The following is a description of a gene set: Genes positively differentially expressed in cell type: cDC2 (conventional dendritic cell type 2) upon treatment with cytokine: IL-13 in mouse lymph nodes in vivo. Mouse Gene Set: CUI_CDC2_IL13_RESPONSE_UP from publication Cui A, Huang T, Li S, Ma A, Pérez JL, Sander C, Keskin DB, Wu CJ, Fraenkel E, Hacohen N (PMID 38057668) species: Mus musculus Cytokines mediate cell-cell communication in the immune system and represent important therapeutic targets. A myriad of studies have highlighted their central role in immune function, yet we lack a global view of the cellular responses of each immune cell type to each cytokine. To address this gap, the authors created the Immune Dictionary, a compendium of single-cell transcriptomic profiles of more than 17 immune cell types in response to each of 86 cytokines (>1,400 cytokine-cell type combinations) in mouse lymph nodes in vivo. A cytokine-centric view of the dictionary revealed that most cytokines induce highly cell-type-specific responses. For example, the inflammatory cytokine interleukin-1β induces distinct gene programmes in almost every cell type. A cell-type-centric view of the dictionary identified more than 66 cytokine-driven cellular polarization states across immune cell types, including previously uncharacterized states such as an interleukin-18-induced polyfunctional natural killer cell state., and this is the list of marker genes: Atp5mc1, Tbc1d16, Psmd1, Morf4l2, Calr, Timm13, Agpat5, Cct5, Rap1a, Rab3il1, Mrpl15, Gtf3c6, Cdh1, C1qbp, Lsm7, Vdac3, Uqcrc1, Syngr2 (NCBI Gene Id 20973), Pla2g12a, Srm, Hes6, Fbl, Psmd2, Rbx1, Trir, Naa10, Cd209e, Gsn, Uap1l1, Pfkp, Aqp3, Uqcr11, Tmem109, Snrpa, Cyb5r3, Rnf7, Pfn1, Pdia3, Ndufa12, Psmb5, AA467197, Pa2g4, Mgl2, Ndufa8, Hspd1 (NCBI Gene Id 15510), Ap2m1, Runx1, Prmt1, Matk, Efhd2, Pdia6, Hsp90ab1, Copz1, Mrc1, Sumo2, Psma7, Tm9sf3, Hnrnpc, Cfp, Timm8a1, Alyref, Vrk1, Nt5c, Sdhc, Park7, Sdf2l1 (NCBI Gene Id 64136), Snu13, Sdhb, Spint2, Tcea3, Glrx5, Mrpl12, Rfc1, Ssr2, Hnrnpk, Ppp1r14a, Hsp90b1, Csnk2b, Atp5pf, Psme3, Arf1, Ddost, Ptprf, Nrp2, Fcgrt, Srsf2, Spcs2, Llph, Aamp, Stt3a, Polr2g, Atp5f1a, Ndufb8, Eif3c, Serbp1, Gar1, Atp5mc3, Casp6, Selenos, Atic, Fkbp4, Slc29a1, Mdh2, Ostc, Hspe1, Gramd4, Bcl7c, Polr2f, Ak2, Tpm3, Jak2 (NCBI Gene Id 98155), Rpn1, Prelid1, Timm22, Spi1, Septin3, Fabp5, Cltc, Il4i1, Wdr18, Lsm4, Lgals1, Trappc2l, Gfra2, Pkm, Fh1, Nfu1, Pdia4, Mtx2, Wdr46, Hspa5, Mrpl54, Ccnd3, Adam8, Ybx1, Mrps28, Slc35b1 (NCBI Gene Id 22233), Tarm1 (NCBI Gene Id 245126), Cyc1, Gapdh, Wdfy4, Psmb10, Kynu, Atp5f1b, Smdt1, Cct3, Vps11, Hnrnpf, Serpina3g, Nop2, Psma2 (NCBI Gene Id 19166), Eif5a, Pecam1, Otulin, Ptges3, Phb2, Magoh, Eif4a1, Sf3b6, Mpc1, Foxn3, Cacybp, Hdgf, Apex1, Dad1, Nudt2, Chchd1, Slc29a3, Eprs1, Bax, Ndufb6, Batf3, Pfdn1, Set, Slc39a7, Edf1, Rsl1d1, Acat1, Ppp1r14b, Sdc4, Adam11, Stip1, Naa38, Nme1, Bola3, Ruvbl1, Bzw1, Krtcap2, Atp5pb, Glipr2, Slc15a3, Lsm2, U2surp, Eif1b, Qpct (glutaminyl-peptide cyclotransferase (glutaminyl cyclase)), Srsf3, Hnrnpab, Timm10b, Bcl11a, Eif1ax, Utp20, Macroh2a1, Ncor2, Psma3, Chchd10, Bcap31, Anp32b, Ndufb9, Mrps15, Hsp90aa1, Psmd4, Arl1, Hfe, Nudcd2, Snrpa1, Fyn, Ywhae, Manf, Psmb7, Lman1, Pdzd4, Cycs, Cdc37, Anpep, Ndufb4, Ldha, Creld2, Nans, Gnl1, Srp14, Rexo2, H13, Sf3b3, Daglb, Idnk, Cd9, Ift20, Bag1, Bzw2, Ctsz, Gadd45gip1, Snx3, Tmed2, Mdh1, Aprt, Erg28 (NCBI Gene Id 97793), Glrx, Spcs3, Ccl17 (C-C motif chemokine ligand 17), Ndufb7, Cope, Pfdn6, Cst7, Mrps24, Ncl, Ece1, Tuba4a, Hspa9, Nup153, Dynll1, Clptm1l, Mfsd5, Myo1e (NCBI Gene Id 71602), Ppib, Eif4g1, Prps1, Kars1, P4hb, Ran, Ddx39a, Cox5a, Tns1, Necap2, Mybbp1a, Arhgdia, Ppa1, Ndufa13, Cct8, Akr7a5, Suclg1, Calm1, Lcp1, Psmc5, Snrpd1, Tomm5, Tmem256, Flt1, Eif5b, Gars1, Ranbp1, Lsm12, Fkbp2, Ccdc86, Mtmr4 (NCBI Gene Id 170749), Tmed10, Gspt1, Nop16, Srsf9, Dok2, Psmb8, Npm3